The following is a description of a gene set: from publication Yevshin I, Sharipov R, Kolmykov S, Kondrakhin Y, Kolpakov F (PMID 30445619) Mouse Gene Set: GADD45A_TARGET_GENES Genes containing one or more binding sites for (Gadd45a) in their promoter regions (TSS -1000,+100 bp) as identified by GTRD version 20.06 ChIP-seq harmonization. studied in species Mus musculus, and this is the list of marker genes: Coil, Rarg, Rbm39, Mars1, Tbrg1, 3110070M22Rik, Aars1, Ptgs2os2, Ddit3, Slc45a4, mt-Nd4, Trp53cor1, Knl1 (NCBI Gene Id 76464), Abcc5, Nfe2l1, Vmn2r-ps18, Nupr1, Pld1, mt-Tn, Nup35 (NCBI Gene Id 76672), Arhgap24, Ccl9, Atf3, Frmd8os, Gm32585, Herpud1, Spen, Prmt3, Gm43391, Gm27252, Spry4, Dcaf6, Smad6, Gm15030, Arl14ep, Ptgs2, Chac1 (ChaC, cation transport regulator 1), Trib1, Lztfl1, mt-Tg, Cotl1, mt-Td (NCBI Gene Id 17728), Sfi1, Mia2, Gm15564 (predicted gene 15564), Tnfaip6, Psmb3, mt-Rnr2, Gm22863, mt-Tp, Ifitm2, mt-Nd6, Olfml3, Xdh, Mpc2, Cebpg, mt-Cytb, Apc, Neat1, 8030487O14Rik, Fndc7, Napepld, Ssu72, Hjurp, mt-Nd1, Ark2c, mt-Tr, Gm19705, H4c14, mt-Tl1, Ncald, Ptgs2os, Hspa9, Hipk3, Enc1, Abhd11, Trpm8, Speer4cos (NCBI Gene Id 75858), mt-Nd3, mt-Tv, Rad23b, Gm9758, Eif4a1, Mmp19, Angpt1, Runx2os2, BC065397, Ndrg1, Srsf2 (NCBI Gene Id 28128), Htra1, Zfp988, Etf1, Gys1, Tmem267, Rpia, Morf4l2, mt-Ty, Hmox1, Nnt, Ston1, Ddr2, Mfsd11, Slc7a11, 4930449E01Rik, Il6ra, Arhgap26, Stk25, Mideas (mitotic deacetylase associated SANT domain protein), Atp1a3, Gm26812 (predicted gene, 26812), Cep295 (NCBI Gene Id 399598), Hmbs, Smarca2, mt-Tc, Psen2 (presenilin 2), mt-Co2, Trib3, Mir6236, Gm9687, Rcc2, A530020G20Rik, Ruvbl2, Ccdc77, Gm8357, Tbce, mt-Ti, mt-Nd4l, Zbtb44, Duxf1, Gm11399